Given this list of marker genes Tyrobp, Trem2, Grn (granulin), Cx3cr1, Il33, here is a description of the gene set: Mouse Gene Set: GOBP_MICROGLIAL_CELL_ACTIVATION_INVOLVED_IN_IMMUNE_RESPONSE species: Mus musculus The change in morphology and behavior of a microglial cell resulting from exposure to a cytokine, chemokine, cellular ligand, or soluble factor, leading to the initiation or perpetuation of an immune response.